The following is a description of a gene set: Human Gene Set: GOBP_REGULATION_OF_HIGH_DENSITY_LIPOPROTEIN_PARTICLE_CLEARANCE Any process that modulates the rate, frequency or extent of high-density lipoprotein particle clearance. High-density lipoprotein particle clearance is the process in which a high-density lipoprotein particle is removed from the blood via receptor-mediated endocytosis and its constituent parts degraded. species: Homo sapiens, and this is the list of marker genes: MIR96, TREM2, MIR33B, GPLD1, MIR185, MIR33A, MIR144, APOC3, LIPG, MIR223 (microRNA 223), MIR302A